The following is a description of a gene set: species: Homo sapiens Vitamin A1 and A5/X pathways Human Gene Set: WP_VITAMIN_A1_AND_A5X_PATHWAYS, and this is the list of marker genes: RXRA, RXRG, RARA (retinoic acid receptor alpha), RARG, RARB, RXRB